Given this list of marker genes GRIN3A, GRIK2 (NCBI Gene Id 2898), FBXL20, APBA1, NRXN2, ADRA2A, PFN2, ADCY1, SYT12, BACE1, PRKCB, FXR1, ADORA3, LAMP5, PRKCG, RAB3A (NCBI Gene Id 96387), DRD2, FXR2, HTR2A, DRD1, CHRNA6, APBA2 (amyloid beta precursor protein binding family A member 2), GIT1, ADORA2A, NGFR, CHRNA5, HIP1, GSK3B, CHRNB3, NOG, FMR1, GIPC1, CHRM2, GLRA3 (NCBI Gene Id 8001), ADORA2B, GRM2, YWHAH, NRN1, here is a description of the gene set: Any process, acting in the presynapse that results in modulation of chemical synaptic transmission. species: Homo sapiens Human Gene Set: GOBP_PRESYNAPTIC_MODULATION_OF_CHEMICAL_SYNAPTIC_TRANSMISSION